Given this list of marker genes ATIC, DELE1, HAS1, RTL6, DOK7, IL36G, TOMM6, QRICH1, ANXA6, LOXL4, ERCC2, PNPLA6 (NCBI Gene Id 10908), CACNB1, PPFIBP2 (PPFIA binding protein 2), CCAR2, PPP1R27, USP11, NOD1, BTBD3, UNC93B1, KRT34, BHMT, CEP41, CYP26B1, MARCO, APOBEC3B, TMEM106C (transmembrane protein 106C), CCR9, AMBRA1, P3H4, GPR4, SLC26A11, CSMD2, PCDHA12 (protocadherin alpha 12), USP8, DNAJC28, MRPS21, TNRC6A, TRIM28, DBN1, PPIF, SCAMP5, TMEM134, TMEM80, GSAP, ZNF846, WDR64, OSBPL7, CCDC12, KHSRP, PRPSAP2, DHX8, REPIN1, RPH3AL, SELENOW, SLC3A1, DNM2, RIC1, AKR7A2, ENTPD2, E2F4, CNR2, ZNF217 (zinc finger protein 217), SOX12, SUPT5H, LIM2, STK32B, TMC4, BID, SDR39U1, EEFSEC, SPATA46, DLX5, KHNYN, DCAF8, PTPRJ, CADM1, GOLT1A, GABRP, TTC5, NUDT15, EFHD2, TSEN34, PPY, B4GALT4, LENG8, HOGA1, PIP4P1, AP5S1, SLC4A4, PPME1, ADAMTSL2, RAB37, CYP2A6, UBE2I, MTURN, AMTN, SNX8, CSNK2B, ADARB1, NAIF1, SLC35G1, ENTR1, NCKIPSD, KDM3B, ARF5, LATS1 (large tumor suppressor kinase 1), FAM98C, ARHGDIB, L3MBTL2, GLT8D2 (NCBI Gene Id 83468), RPUSD1, MARCHF10 (membrane associated ring-CH-type finger 10), BBOF1, PPT2, TXNL4A, CRB3, ZDHHC12, LFNG, NEDD8, ANKRD27, TNFRSF4, CALR, TPTE, RNASEK, RANBP6, MBTPS1, IFRD2, FFAR2, GATM, NEURL1B, ACTN1, UBE2W, NUP210, GIGYF1, AAK1, ITGAX, ZC3H12D, CSF2RA, ATP5MC2, DBNL, PSMB9, PSME1, TOMM40, KLHDC3, NXF1, FLT3, POU6F2, VRK2, SPDYE18, EVL, C19orf67, PIANP, ARHGAP30, ECE1, PMM2, TM4SF5, STYXL2, SRSF11, CRPPA, DECR2, CD38, ATXN2L, ALOXE3, PSAP, DENND1C, LAPTM4A, TMLHE, SETD5, ARFIP2, TOX2, THEM6, CTDP1, DOK2, UGGT2 (NCBI Gene Id 80239), CDON, TMPO, SBF1, GPBP1L1, SNRPA, CA10, ADARB2, ACSM5, CASR, UPK1B, FADD, SLC20A2, AHSG, DNAJB12, SORT1, SEPTIN1, KMO, TP53RK, FAT2, DNA2, PECAM1, SMDT1, AQP6, VHL (NCBI Gene Id 8056), SYMPK, here is a description of the gene set: Human Gene Set: GSE29164_DAY3_VS_DAY7_CD8_TCELL_TREATED_MELANOMA_DN from publication Kerkar SP, Goldszmid RS, Muranski P, Chinnasamy D, Yu Z, Reger RN, Leonardi AJ, Morgan RA, Wang E, Marincola FM, Trinchieri G, Rosenberg SA, Restifo NP (PMID 22056381) Myeloid-derived cells comprising the tumor stroma represent a heterogeneous population of cells critical to the structure, function and growth of established cancers. We have recently found that engineering tumor-specific CD8+ T cells to secrete IL-12 (IL-12TD) can lead to striking improvements in T-cell activity against established melanomas in murine models. Surprisingly, IL-12-dependent enhancement of CD8+ T-cell anti-tumor function did not occur through direct ligation of receptors on lymphocytes or NK cells. Instead, IL-12 sensitized host bone marrow-derived tumor-stromal cells, partly through interferon-gamma, to indirectly enhance the effects of adoptively-transferred T cells. Direct presentation of antigen by tumor was not necessary, but MHC class I expression on endogenous cells was essential for IL-12 mediated anti-tumor enhancements. Upon successful treatment with IL-12TD cells, we observed the selective elimination of tumor-infiltrating CD11b+ F4/80+ macrophages, CD11b+/ClassII+/CD11c+ dendritic cells and CD11b+/Ly6C+/Ly6G- but not CD11b+/Ly6C+/Ly6G+ myeloid-derived suppressor cells within regressing lesions. These results are consistent with a model whereby IL-12 triggers the maturation of myeloid-derived cells into competent antigen cross-presenting cells. Licensed recognition of these antigens by effector T cells may in turn trigger the collapse of the tumor stroma and aid in the regression of large vascularized lesions. studied in species Homo sapiens Genes down-regulated in mock treatment during adoptive transfer therapy of B16 melanoma: day 3 versus day 7.